The following is a description of a gene set: from publication Tsutsumi T, Kuwabara H, Arai T, Xiao Y, Decaprio JA (PMID 17998335) studied in species Mus musculus Genes differentially expressed in E18.5 whole embryos upon knockout of FBXW8. CUL7 binds to SKP1, RBX1, and FBXW8 to form a cullin-RING ligase, or an SKP1-cullin-F box protein complex. The targeted disruption of the Cul7 gene in mice results in significant reduction in embryo size and neonatal lethality. In humans, CUL7 was found to be mutated in the 3-M dwarfism syndrome characterized by severe pre- and postnatal growth retardation, indicating that CUL7 is closely associated with human and mouse growth. We generated mice lacking Fbxw8 by gene trapping. Similar to Cul7(-/-) animals, Fbxw8(-/-) embryos and placentas were smaller than wild-type and heterozygous littermates and placentas. Approximately 30% of the expected number of Fbxw8(-/-) mice survived birth, but these mice remained smaller than their wild-type and heterozygous littermates throughout postnatal development. FBXW8 expression was detected in most organs of wild-type mice examined, and the organs in Fbxw8(-/-) mice were smaller than those in wild-type mice. Fbxw8 expression levels were highest in skeletal muscle, cartilage, and lung tissue. Expression profiling revealed elevated levels of insulin-like growth factor binding protein 1 (IGFBP1) transcripts in Fbxw8(-/-) embryos. Furthermore, we observed increased levels of IGFBP2 in Cul7(-/-) as well as Fbxw8(-/-) fibroblasts. These results demonstrate that the FBXW8-CUL7 complex plays a significant role in growth control. Human Gene Set: TSUTSUMI_FBXW8_TARGETS, and this is the list of marker genes: SFSWAP, RYR1, PCGF5, MYBPC2, ACTN3, MYPN, IGFBP1, FBXW8, ATP2A1